Given this list of marker genes CLDN4, BMP2, CLDN20, CLDN2, CLDN6, CLDN5, CLDN3, CLDN17, CLDN11, CLDN12, CLDN16, CLDN18, CLDN10, CLDN19, CLDN15, CLDN7, CX3CL1, CLDN23, CLDN1, CLDN22, CLDN8, CLDN9, CLDN14, here is a description of the gene set: studied in species Homo sapiens The attachment of one cell to another cell via adhesion molecules that do not require the presence of calcium for the interaction. Human Gene Set: GOBP_CALCIUM_INDEPENDENT_CELL_CELL_ADHESION_VIA_PLASMA_MEMBRANE_CELL_ADHESION_MOLECULES